Given this list of marker genes SLC39A10, KRTAP2-3, MAP3K1, RPAP3, IFT56, PTPN4, AKAP9, ZNRF2, SEC62, SPAST, DDI1, SCAF11, NPTX1, OLAH, ISY1, TRIM2, AP1G1, AFAP1, FLRT3, GNA12, SERPINE2, MTHFD2, XRN2, CTDSPL2, CNR1, ADH1B, FAM222A, CUL2, SORCS3, EXT2, JAG1, ASAP2, KDM6A (lysine demethylase 6A), PCDH17, G6PC2, ANKRD17, PXN, C9orf40, ZBTB43, CAMK2D, GPR137C, PNOC, C17orf100, GABRA1, GCNT1, HIC2, ELOVL4, DDAH1, ABCC5, CHSY3, ARL6IP1 (NCBI Gene Id 56166), GIMAP2, PPP2R5E, RNGTT, ZNF706, NRG1, TPPP, AFDN, CALD1, ZFP36L2, CPEB4, BCAR3, LRRC4C, NAA25, KLHL3, RBM27, CYRIB, ITPK1, CNTLN, CTH, CD2AP (NCBI Gene Id 25916), ADCY1, FAM193A, G3BP2, SINHCAF, SH3GLB1, LRRTM2, ITPKC, MIER1, HS3ST5, HCN4, SEMA3A, UBE2J1, ECM2, ZHX1-C8orf76 (NCBI Gene Id 100533106), PPP1R3C, TPGS2, PHYHIPL, TNFRSF11B, SRPK1, PSG1, SKI, PTER, SEPTIN10, CNIH3, DTNA, EVI5, PCDHB15, FGF20, ANKRD46, DGKI, NUTF2, GCSAML, PAWR, GALNT7, HTRA3, MPP7, CAD, LYSET, ADAMTSL3, ADGRG2, SCD, AK3, ATP1B1, MON2, SLC7A1, CPEB3, MPRIP, RAPH1, SCARB1, FBXL22, SOS2, TMEM170A, RILPL1, HAS1, ZMYM2, MAP3K5, AUNIP, SLITRK6, PRPS2, BTBD7, ITGA3, LRP2, PTPN3, RNF141, TLCD3A, KDR, here is a description of the gene set: from publication Chen Y, Wang X (PMID 31504780) studied in species Homo sapiens Genes predicted to be targets of miRBase v22 microRNA hsa-miR-936 in miRDB v6.0 with MirTarget v4 prediction scores > 80 (high confidence targets). Human Gene Set: MIR936